Given this list of marker genes Wtip, Ccne1, Nr3c1, Gng3, Cox7b, Hspa1b, Sqstm1 (sequestosome 1), Egln3, mt-Co2, Itfg2, Capzb, Higd1c, Hbb-bt, Dync1i2, Eif2s2, Ufd1, Psmd2, Nprl3, Atp6v1g1, Nup88, Sh3bp4, Uba52rt, Hira, Prdx6, Nup37, Rbbp7, H2ac12, Psma6, Tuba1a, Xpo1, Ramp2, H1f2, Atp6v1e2, Rps6ka1 (ribosomal protein S6 kinase polypeptide 1), Eed, Flcn, Camk2d, H4c17, Nr3c2, Bag3, Cox7a2l, Ccna2, Alb, Stoml2, Hspa12a, H2ac6, H2bc24, Dctn3, Mapkapk5, Map1lc3b, Psma1, Castor2, H4c1, Pgr, Nup160, Acd, Psmd3 (proteasome (prosome, macropain) 26S subunit, non-ATPase, 3), Ptges3, Map2k6, Cox7a1, Sod3, Dynll2, Kics2, Atp6v1a, Ptk2, Psmb1, Prdx2, Psmb4, Gstp2, Ajuba, Nploc4, H2ac24 (NCBI Gene Id 319171), H4c12, Kdm6b, H2ac8, Skp2, H2ac22, Prkar1b, Dctn4, Aaas, H2bc8, Atp6v0e2, Anapc11, Psmd12, Nfe2l2, Szt2, Anapc1, Gna11, Cox6a1, Ube2e1 (NCBI Gene Id 22194), H4c16, Nup35, Anapc2, Fzr1, Hspa14, H2bc9, Lamtor2, Psma3 (proteasome subunit alpha 3), Dync1li1, Nup85, Actr10, Terf2ip, Psmb5, Nup42, Eif2s1, Vhl, H2bc15, Rraga, Anxa2, Cdkn1b, Rragc, Gng4, Ezh2, Capza3, Nudt2, Ywhae, Ppp2r2a, Capza2, Dnaja4, H2bc1, Gsk3b, Trp53, H4c9, Tubb4a, Txnrd1, Med1, Dnajc2, Mre11a, Anapc5 (anaphase-promoting complex subunit 5), Cox7a2, Nup214 (NCBI Gene Id 269260), H2bc11, H1f4, Prdx1, Ncf2, Creb3, Gpx5, Yme1l1, Ikbkg, Atm, Helz2, Tubal3, Tuba1b, H2ac15, Ero1a, Atp6v1h, Rps19bp1, Pgrmc2, mt-Co1, Akt1, Ncf1, Cdk2, Hspa8, Map2k3, Ets1, H2ac10, Ets2, Gpx3, Atp6v1f, Hif1a, Rictor, Mdm2, Gng10, Atp6v0c, Trpv4, H2ab3, Prkar1a, H2ac18, Cox5a, Hspa2, Cebpb, Ubn1, Lamtor5, Nup54, Trim21, Atp6v0b, Nfkbia, Nup50, Rps27a, Atp6v1e1, Tbl1x, H4c3, Anapc7, Ppp2ca, Mapk1, Hsbp1, Depdc5, Psma2, Prkaca, Kptn, Cul1, Stip1, Atp6v0d1, Cybb, Ube2d2a, Tnik, Cdk6, H2bc3, Tubb3, Pde4d, Mapk9, Tuba1c, Hif1an, Gnb4, Sirt3, Gpx8, Ep400, Rpa1, Ubb, Cabin1 (NCBI Gene Id 547317), Fnip2, Capns1, Psmd8, H2bc26, Gng7, Akt3, Ppara, Cdc16, H2bc14, Rpa2, Ccna1, Carm1, Keap1, Abcc1, Cul2, Rela, Hsph1, H4c6, Akt1s1, Rheb, Seh1l, Gnb1, Sirt1, Esr1, Apoa1, Itgav, Psmd6, Ep300, Cyba, Foxo3, Cul3, Sesn2, Ndc1, H2ab2, Atp6v0d2, Map2k4, Gng13, Bach1, Phb2, Ncoa1, H2aj, H4c4, Dnaja2, H2az2, Sod2, Actr1a, Anapc4, Crebrf (CREB3 regulatory factor), Cox5b, Rps6ka2, Creb3l3, Oma1, Pdpk1, Itgb3, Nbn, Cdkn1c, Terf2, Blvra, Dctn6, Anapc16 (anaphase promoting complex subunit 16), Bag2, Gng12, Apob, H1f0, Dctn1, H2ac4, Mafk, Cat, Id1, Capns2, Mapk3, Slc38a9, Eif2ak1, Psmc1, Ppp2r1a, Tubb6, Calm1, Camk2a, Hif3a, Map3k5, Psmb7, Hmox1, Cox6b2, H2bc7, Dctn2, Akt2, Ehmt1, Gng11, Fos, Sod1, Ppp2r1b, Hbb-bs, Ranbp2, Epas1, Sin3a, Gng8, Gnb2, Hdac3, Egln1, mt-Co3, Rxra, H2ax, Nup210, Psmd11, Skp1, Chuk, Calm3, H3f4, Mios, Terf1, Wdr24, Gngt1, Cox4i2 (NCBI Gene Id 84682), Ptpn1, Wdr59, Gsr, Uba52, Ncf4, Jun, Gng2, Mbtps1, Camk2g, Psmc4, Itgb1, Tuba4a, Prdx5, Psmc6, Hikeshi, H4c11, Atp6v1c1, Hmga2, Hsp90aa1, Vcp (NCBI Gene Id 269523), Ikbke, Arnt, Dync1i1, H4c2, Ube2d3, Ncoa2, Cox6b1, H2bc21, Pkn2, Vcl, Sin3b, Atf6, Dctn5, Atp6v1g3, Hspa1a, Tuba3a, Mlst8, Itga5, Anapc10, Camk2b, Rae1, Rragd, Txn2, H2bc12, Rpa3, Anapc15, H4c18, Psmc5, Dele1, Ly96, Mapkapk3, Psmb3, Mdm4, Nup205, Psmc3, Hsf1, Cox7c, Hspa12b, Psma5, Mtor, Ubc, Nup155, Hmga1b, Pom121, Fbxl17, Nup153, Hsp90ab1, Fkbp4, Psma4, Calcrl, Ube2s, Dynll1, Dnajb6, Nup58, Tgs1, Bag4, Cdc23, H4c14, Gstp1, Lamtor3, Kat5, Tuba3b, Hspa4l, Tuba8, Ehmt2, Gnas, Atp6v0e, Fabp1, Cdc26, Cited2, Atp6v1c2 (NCBI Gene Id 68775), Nup188, Ubxn7 (NCBI Gene Id 381042), Cox8a, Hspa5, Suz12, Psmd13 (NCBI Gene Id 23997), Cdkn1a, Clec1b, Ccs, St13, Ncor2, Mapk8, P4hb, H2bc13, Ube2d1, Nox4, Bag5, Sesn1, Rps6ka3, Tlr4, Cdkn2b, Nfkb1, Ndufa4 (NCBI Gene Id 17992), Bmt2, Srxn1, Tubb2a, Tpr, Yap1, Mapk10, H2ac11, Dnajb1, H1f5, Rbbp4, Nprl2, Psmd1, Psmb6, Hspa13, Ikbkb, Cox8c, Hspa9, Sec13, Cdc27, Fnip1, Atp6v1b1, Hmga1 (high mobility group AT-hook 1), Atp6v1b2, Map2k7, Smarcd3, Cryab, H2ac7, Cdk4, Eef1a1, Nup62, Adrm1, Ccne2, Ube2c, H2ac13, Nup133, Psma7, Castor1, Hspa1l, H13, Mul1, H2ac19, Tubb2b, Dnaja1, Prkci, Psmd14, Abl1, Elob, Rbx1, H2ac23, Gpx7, H2bc4, Tubb4b, Atp6v1g2, Mapk14, Mapkapk2 (MAP kinase-activated protein kinase 2), Rad50 (NCBI Gene Id 19360), Mink1, Cox6a2, Prr5, Pot1a, Slc46a1, Eif2s3x, Capn2, Rb1, Gm10053, Lmnb1, Dync1li2, Cox6c, Dync1h1, Prkaa2, Map4k4, Fn1, Prdx3, Mt2, Gng5, Rragb, Nup43 (nucleoporin 43), Blvrb, Gnaq, P2ry2, Cycs, Atp6v1d, Mapk7, Chd9, Nup93, Nos3, Gpx1, Calm2 (NCBI Gene Id 75700), Tcirg1, Lamtor4, Gnb3 (NCBI Gene Id 14695), Lamtor1, Hba-a1, Fkbp5, Gpx6, Eloc, Atf6b, Hmox2, Mapk11, Tubb1 (NCBI Gene Id 72817), H1f1 (H1.1 linker histone, cluster member), Nup98, Psmc2, H2ac20, Psmd7, H2ab1, Erf, Hspb8, Rptor, Adm, Ern1, Prkacb, Limd1, Mapkap1, Mbtps2, Cox4i1, H4c8, Tbl1xr1, Mt3, Psmb2, Gnb5, Hspa4, Txn1 (NCBI Gene Id 22166), Egln2 (NCBI Gene Id 97399), H2bc22, H2bc6, H2bc23, Ar, Gngt2, Asf1a, Gpx2, Hdac6, Bag1, Txnrd2, Nup107, here is a description of the gene set: species: Mus musculus Mouse Gene Set: REACTOME_CELLULAR_RESPONSES_TO_STIMULI Cellular responses to stimuli